The following is a description of a gene set: studied in species Mus musculus Mouse Gene Set: chr16B2, and this is the list of marker genes: Tmem44, Bdh1, Cpn2, Dlg1, Gp5, Gm15703, Gm26562 (predicted gene, 26562), Gm18237, Wdr53, Ncbp2as2, Fam43a, Ppp1r2, Gm8253, Ccdc50, Atp13a4, Hmgb1-ps6, Gm32312, 1700007E05Rik, AV205837, Gm536, Gm46565, Gm25848, Gm10823 (NCBI Gene Id 100038623), Gm15743, Atp13a5, Gm49767, Gmnc, Gm49754, Hes1, Mir1946a, 9030404E10Rik, Cep19, Opa1, Uts2b, Lrrc15, Acap2 (NCBI Gene Id 78618), Pak2, Pigz, Fgf12, Gm15970, Gm20319, Senp5, Plaat1, Gm15742, Tmem207, Fbxo45, Nrros, Apod, Mb21d2, 4632428C04Rik, Bex6, Gm18234, Ostn (NCBI Gene Id 239790), Gm15694, Gm26419, Gm1968, Gm15696, Pigx (phosphatidylinositol glycan anchor biosynthesis, class X), Xxylt1, Gm25375, 1700025H01Rik, Gm41442, Gm20040, Gm6029, Gm46560, Cldn1, Gm18236, Lsg1, Il1rap, Gm24879, Ncbp2, Meltf, Mir690, Gm34256, Cldn16, Gm32679, Atp13a3